The following is a description of a gene set: Signaling events mediated by HDAC Class II from publication Schaefer CF, Anthony K, Krupa S, Buchoff J, Day M, Hannay T, Buetow KH (PMID 18832364) Human Gene Set: PID_HDAC_CLASSII_PATHWAY species: Homo sapiens, and this is the list of marker genes: NR3C1, GNB1, HDAC10, HDAC7, MEF2C, SUMO1, TUBA1B, BCOR, GNG2, HDAC3, YWHAE, TUBB2A, SRF, XPO1, HDAC9, ANKRA2, GATA2, UBE2I, RANBP2, RAN (RAN, member RAS oncogene family), HDAC6, GRK2, ESR1, HSP90AA1, HDAC4, RFXANK, HDAC11, HDAC5, CAMK4, NCOR2, YWHAB (NCBI Gene Id 7529), GATA1, RANGAP1, BCL6